The following is a description of a gene set: Mouse Gene Set: GOBP_WALKING_BEHAVIOR studied in species Mus musculus The behavior of an organism relating to the progression of that organism along the ground by the process of lifting and setting down each leg., and this is the list of marker genes: Cacna1a, Ctns, Zfp212, Sptbn4, Cwh43, Atg7, Rnf170, Cntn2, Dab1, Kcnma1, Klhl1, Enpp1, Ulk4 (unc-51-like kinase 4), Uchl3, Oxr1, Arrb2, Htra2, Epha4, Cntnap2, Borcs7, Ndufs4 (NCBI Gene Id 77728), Psap, Uchl1, Abl2, Hexa, Atp1a3, Pmp22, Abhd12, Spg11, Zmpste24, Minar2, Drd2, Fkrp, Drd1, Kcnj10, Efnb3, Cln8, Glrb, Cend1, Hipk2, Pcdh15, Axin1, Cacnb4 (calcium channel, voltage-dependent, beta 4 subunit), Scn1a (NCBI Gene Id 227987), Chat, Chd7, Agtpbp1, Gbx1, Large1, Dmrt3, Cacna1c, Dmd, Zic1, Idua, Mapt, Trh, Glra1, Fxn, Scn8a, Npc1